Given this list of marker genes EIF2S1, PML, EIF2AK4, RBM4, KRT13, RPS6KA1, NPM1, DNAJC3, PRKCH, IMPACT, ENSG00000293600, RPS6KA3, MAP3K20, PPP1CA, PPP1R15A, SESN2, NCK1, EIF4G1, DDX3X, EIF2AK3, NCK2, ANG, here is a description of the gene set: studied in species Homo sapiens Human Gene Set: GOBP_REGULATION_OF_TRANSLATION_IN_RESPONSE_TO_STRESS Modulation of the frequency, rate or extent of translation as a result of a stimulus indicating the organism is under stress. The stress is usually, but not necessarily, exogenous (e.g. temperature, humidity, ionizing radiation).